Given this list of marker genes PMAIP1, OR2J2, CDC42EP4, SLC26A1, GRAPL-AS1, PGC, HGFAC (HGF activator), FKBP11, CAMK2A, MTURN, CWF19L1, SPAM1, PCDH20, MANEAL, ACBD6, ZNF140, ACKR3, MTMR2, GABRG3, KCND2, DDX4, KLK8, NPSR1-AS1, SLCO1B1, ERVH48-1, PTPRD, PRKACG, KIF19, LINC00574, EEIG2 (NCBI Gene Id 284611), ENPP7, MIRLET7BHG, CSPG5, FBXL6, IQCK, EVC, STXBP5-AS1, CERS1, FARSB, DDI1, MEGF11, SEMA6B, ADCK1, CFAP99, TBX3, PCDHB7, ATXN8OS, DBP, PELI2, CASZ1, ITGB6, SHE, ADH4, EMX2, ZNF319, MRPL14, KHDRBS2, LRP5, AMH, SLC27A6, AMPD2, RNF150, CYP1B1-AS1, MROH6, KCNV2, XPO4, RNF2, VN1R3, ABCC4, STAB2, BTN2A2, REG1A, DISC1, NUP62, ARMC5, WFDC6, RETN, IRX5, CRISP1, ASCL1, MMP7, PDE1A, TACR2, GATC, C19orf84, VSNL1, KRT6B, RNF175, EIF3LP3, FAM216A, NDOR1, IL10, SSC4D, KRTAP5-AS1, IGSF10, CHSY3, CFAP126, MAP3K5, ITIH3, TBC1D8, CDC20B, TFDP3 (transcription factor Dp family member 3), TNFRSF8, DNM1P46, ZNF683, TCF7L2, NME8, KCNJ3, ARHGEF40, IER3, MATN3, XDH, HEPACAM2, LINC02875, SLC25A31, LINC00543, REN, LEKR1, CALR3, NFKBIA, FGF13-AS1, CLIP2, ZCCHC18, C1QA, SLC26A3, PHACTR1, LINC01123, PCDHGB7, STK16, GPC6, SSTR2, NFE2L1, PLD6, SLC4A5, LRRC17, ABCC8, STAC2, ABCG4, MTTP, HNMT, HCG4B, B4GALT2, CEP170B, UTP25, TMPRSS11E, DNAJB13, IRF5, ELAVL3, RBP4, LINC00896, KCNQ3, HDC, LURAP1, B3GALT5, FAM133A, C3, M1AP (NCBI Gene Id 130951), CFAP95-DT, C5AR2, TESC, ZNF483, TP53I11, KCNK1 (NCBI Gene Id 3775), NAV3, FOXO6, EFNA3, SLITRK6, NR5A1, NRTN, HABP2, RAPGEF3, SLAMF1, TMEM200C, GADD45B, CFC1, TNFRSF14, SAMD11, MC4R, SLC7A10, MIR3945HG, TNIP2, TMEM132C, OR1F1, HCST, SSPOP, FGFRL1, PTPN3, COL16A1, RIPK4 (NCBI Gene Id 54101), ICAM1, PER1, SLC45A1, C20orf202, GBX1, PARP3, here is a description of the gene set: Human Gene Set: GSE23114_WT_VS_SLE2C1_MOUSE_PERITONEAL_CAVITY_B1A_BCELL_DN Sle2c1 is an NZM2410-derived lupus susceptibility locus that induces an expansion of the B1a cell compartment. B1a cells have a repertoire enriched for autoreactivity, and an expansion of this B cell subset occurs in several mouse models of lupus. Here we showed that expression of Sle2c1 enhances NZB cellular phenotypes that have been associated with autoimmune pathogenesis. A combination of genetic mapping and candidate gene analysis presents Cdkn2c, a gene encoding for cyclin kinase inhibitor p18INK4c (p18), as the top candidate gene for inducing the Slec2c1 associated expansion of B1a cells. A novel SNP in the Cdkn2c promoter is associated with a significantly reduced Cdkn2c expression in the splenic B cells and B1a cells from Sle2c1-carrying mice, which leads to defective G1 cell cycle arrest in splenic B cells and increased proliferation of Pc B1a cells. As cell cycle is differentially regulated in B1a and B2 cells, these results suggest that Cdkn2c play a critical role in B1a cell self renewal, and that its impaired expression leads to an accumulation of these cells with high autoreactive potential. from publication Xu Z, Potula HH, Vallurupalli A, Perry D, Baker H, Croker BP, Dozmorov I, Morel L (PMID 21543644) Genes down-regulated in peritoneal cavity B lymphocytes: wildtype versus lupus susceptibility locus Sle2c1. studied in species Homo sapiens